The following is a description of a gene set: species: Homo sapiens Human Gene Set: CATGTAA_MIR496 Genes having at least one occurence of the motif CATGTAA in their 3' untranslated region. The motif represents putative target (that is, seed match) of human mature miRNA hsa-miR-496 (v7.1 miRBase)., and this is the list of marker genes: PAPOLG, KHDRBS3, PPP3R1, HSPE1, DPP10, SATB2 (NCBI Gene Id 80104), PPP6R3, KBTBD8, MYT1L, ARID4B, TTN (NCBI Gene Id 7847), EMP1, GOLPH3, CDKN2C, ZMYM2, TLK1, LRIG1, ADNP2, ELAVL1, CAPRIN1, MINAR1, SLBP, KLF3, MAP2, COL15A1, VCPIP1, DLX5, HACE1, CPEB4, MAT2A, ZCCHC14, OAZ2, GRIA2, ALYREF, UBE2V2, PTPN11, ZIC1, SEC62, YPEL5, NXPH1, MNT, DNAJB14, YTHDF3, COX5A, DDX3X, LDB2, HMGCS1, SEMA6D, LENG8, RNF220, DMD, UBE2W, KCNS3, BACH2, TIA1, PURG, B4GALT5, ROBO1, STON1, BAHD1, RSBN1, PDE3A, ZNF507, CANX, ZMAT2, ANKRA2, KIAA1217, RAP2C, CHML, CLASP2, PPP4R3A, PRPF39, SEPTIN11, VEZF1, LAMP2, YWHAZ, CHD7, CREBRF, MAFB, LRRN3, NIPA1, PAX5, LRRTM2, USP42, DDX3Y, SETD2, PRDM10 (PR/SET domain 10), DAZAP2, MAPK9, NPTN, FBN1, ELF2, MAP3K3, NBEA, B4GALT6, UBR5, MTDH, UBE2G1, ASXL2, ZNF420, HECTD2, WTAP, MEF2C, HPN, SLC25A36, PARVA, VSTM2A, MEIS2, KHDRBS1, GJA1, HNRNPR, MIER3, RAD21, NEUROD1 (NCBI Gene Id 7853), FAM133B, HOXB3, RAB5C, HOXD1, MTMR6, BDNF, PCF11, UBE2A, TOMM70, SEMA6A, CAMTA1, TRAPPC11, ESYT2, SLC26A7, KCNH8, TOX, HIVEP2, PAFAH1B1, PTHLH, TECPR2, TMEM33, PLEKHA5, ITM2B, PHF14, QKI, TMEM47, TNRC6B, TAF4, PRDM1, SKP1, PSMD11, PAX3, CACNA1C, CALML4, BACH1, ZNF536, YAF2, TPP2 (tripeptidyl peptidase 2), DACH1, NAV3, LEMD3, EPHA3, TSHZ3, BRCA1, SLC25A16 (solute carrier family 25 member 16), OLFM1, NSG2, FBXO8, MSL2, ZNF331 (zinc finger protein 331), ASCL1, DR1, CAAP1, CNTNAP2, DPY19L3, KLHL1, PAIP1, SLITRK5 (NCBI Gene Id 26050), ANGPT1, REV1, VAMP3